Given this list of marker genes SLC6A5 (NCBI Gene Id 9152), SLC38A3, SLC1A7, SLC38A4, SLC1A6, SLC6A9 (NCBI Gene Id 6536), SLC6A8, SLC6A20, SLC6A18, SLC6A15, SLC6A14, SLC1A3, SLC1A2, SLC6A13, SLC6A11, SLC38A7, SLC6A7 (solute carrier family 6 member 7), SLC6A1, SLC6A6, SLC38A2, SLC38A1, SLC6A12, SLC1A1, here is a description of the gene set: species: Homo sapiens Enables the transfer of a solute or solutes from one side of a membrane to the other according to the reaction: amino acid(out) + Na+(out) = amino acid(in) + Na+(in). Human Gene Set: GOMF_AMINO_ACID_SODIUM_SYMPORTER_ACTIVITY